Given this list of marker genes Cited2, Tfap2e, Sumo1, Myc, Cited4, Atad2, Npm1, Ep300, Esr1, Cga, Tfap2d, Cited1, Tfap2a, here is a description of the gene set: species: Mus musculus part of: Generic Transcription Pathway This event has been computationally inferred from an event that has been demonstrated in another species.<p>The inference is based on the homology mapping from PANTHER. Briefly, reactions for which all involved PhysicalEntities (in input, output and catalyst) have a mapped orthologue/paralogue (for complexes at least 75% of components must have a mapping) are inferred to the other species. Reactome Pathway: Transcriptional regulation by the AP-2 (TFAP2) family of transcription factors electronically inferred by orthology from the curated human pathway